Given this list of marker genes UBR2, HUWE1, BRCA1, TRIM37, RNF2, PCGF5, BARD1, RNF168, PCGF3, UHRF1, RNF20, DTX3L, MSL2, here is a description of the gene set: Human Gene Set: GOMF_HISTONE_UBIQUITIN_LIGASE_ACTIVITY species: Homo sapiens Catalysis of the transfer of ubiquitin to a histone substrate.